Given this list of marker genes Cd55, Syk, Tnfsf4, H2-T23, Irgm1, Cd80, Card11, Cd3e, Il23a, Cd244a, Prkcq (protein kinase C, theta, NCBI Gene Id 99373), Xcl1, Ptprc, Cd55b, Il18, Ccr2, Cd81, Cd24a, Rasal3, Tyk2, Ripk2, Jak2, Blm, Il12b, Zap70, Ptpn22, Tgfbr2, Cd28, here is a description of the gene set: Any process that activates or increases the frequency, rate or extent of alpha-beta T cell proliferation. studied in species Mus musculus Mouse Gene Set: GOBP_POSITIVE_REGULATION_OF_ALPHA_BETA_T_CELL_PROLIFERATION